Given this list of marker genes Sting1, Lsm14a, Trim6, Fadd, Rbm47, Nlrc5, Rnf185, Irf7, Usp29, Trim41, Mmp12, Ube2k, Trim56, Zbp1, Irf3, Usp27x, Wnt5a (wingless-type MMTV integration site family, member 5A, NCBI Gene Id 77565), Mavs, Tbk1 (TANK-binding kinase 1), Ikbke, here is a description of the gene set: species: Mus musculus Any process that increases the rate, frequency or extent of a type I interferon-mediated signaling pathway. Mouse Gene Set: GOBP_POSITIVE_REGULATION_OF_TYPE_I_INTERFERON_MEDIATED_SIGNALING_PATHWAY